The following is a description of a gene set: species: Mus musculus electronically inferred by orthology from the curated human pathway This event has been computationally inferred from an event that has been demonstrated in another species.<p>The inference is based on the homology mapping from PANTHER. Briefly, reactions for which all involved PhysicalEntities (in input, output and catalyst) have a mapped orthologue/paralogue (for complexes at least 75% of components must have a mapping) are inferred to the other species. part of: Deadenylation-dependent mRNA decay Reactome Pathway: mRNA decay by 5' to 3' exoribonuclease, and this is the list of marker genes: Dcp1a, Edc4, Lsm4, Edc3, Lsm1, Lsm6, Dcp2, Lsm2, Patl1